The following is a description of a gene set: An integral membrane complex that possesses NADH oxidoreductase activity. The complex is one of the components of the electron transport chain. It catalyzes the transfer of a pair of electrons from NADH to a quinone. species: Mus musculus Mouse Gene Set: GOCC_NADH_DEHYDROGENASE_COMPLEX, and this is the list of marker genes: Ndufs2, Ndufs1, Ndufb6, mt-Nd3 (mitochondrially encoded NADH dehydrogenase 3), Foxred1, Ndufb10, Ndufv1, Ndufb11b, Ndufb9, mt-Nd5, Ndufs4, Ndufa6, Ndufv2, Ndufs5, mt-Nd6, Ndufs8, mt-Nd4, Ndufa8, Ndufa2, Ndufs7 (NCBI Gene Id 75406), Ndufb8, Ndufa7, Ndufa11, Ndufc1, Ndufs6b, Ndufb7, Ndufa3, mt-Nd1, Ndufa1, Dmac1, Ndufb4c, Ndufs6, Ndufc2, Dmac2, Ndufab1, Ndufa13, Ndufa9, Ndufb4, mt-Nd2, Ndufa10, Ndufa12, Ndufa5, Ndufb4b, mt-Nd4l, Ndufb11, Ndufa4, Ndufb3, Ndufa11b, Ndufs3, Ndufab1-ps, Ndufb5, Wdr93, Ndufb2, Ndufv3, Ndufb1, Ndufaf2